Given this list of marker genes CILK1, TACR3, TOE1, HMGA2, HSD3B2, IGF2, OPHN1, CDKN1C, PLAG1, RTTN, SIN3A, GATA4, TRRAP, THOC2, SAMD9, MINPP1, FANCF, here is a description of the gene set: Microphallus Length of penis more than 2 SD below the mean for age accompanied by hypospadias. species: Homo sapiens Human Gene Set: HP_MICROPHALLUS